Given this list of marker genes HLA-B, LMAN1, TBL1XR1, NRAS, NR1H4, SERPINC1, SLC4A1, SHOC2, AGGF1, SRD5A3, CLPB, ATP6V1A, GPC3, H19, VWF, HSD17B10, NGLY1, PROC, AMACR, PHOX2B, THBD, PEX2, PIK3CA, CACNA1S, STX5, PEX11B, HAVCR2, HLA-DQB1, SLC19A1, GBA1, GATA2, ITGB2, OSTM1, TRIP13, MCFD2, PEX10, SLC30A10, TERC, DLD, GP9, BCOR, NOP10, DKC1, MPI, MTTP, HSD3B7, PRF1, AGA, ACD, ALG6, PEX19, PEX5, RFT1, COG2, RIT1, NUMA1, PEX12, TRMU, ALG13, SLC25A13, EPB42, F2, HADH, GP1BA, TRIM28, MPDU1, VKORC1, COX16, KRAS, HLA-DQA1, SERPINF2, F8, DIS3L2, OTC, TINF2, MRAS, HRG, GATA6, RAF1, WT1, NABP1, MST1, PEX6, TEK, HACE1, TCF4, STAT2, LIN28B, COG8, ALK, F7, SEMA4D, SPRED2, FAH, HMGCL, MICOS13, ZBTB16, MPV17, EPHB2, BRCA2, ANK1, B4GALT1, MYD88 (NCBI Gene Id 4615), LMO1, NLRC4, HBB, GFI1B, EFL1, FOXP2, CFH, SPTA1 (NCBI Gene Id 6708), ORAI1, PEX3, RRAS2, LYST, MCM10, TNFRSF9, SSR4, POU6F2, RRAS (NCBI Gene Id 6237), HELLPAR, DPAGT1, SLC37A4, FGG, LARS1 (leucyl-tRNA synthetase 1), SOS1, KLKB1, FGB, ADK, GPR35, ALG8, STAT5B, F5, THBS2, PEX26, PEX13, AKR1D1, NHP2 (NCBI Gene Id 55651), F10, F9, SERAC1, P4HA2, IRF2BP2 (NCBI Gene Id 359948), PEX1, KNG1, PEX14, PRKAR1A, MEFV, SOS2, SPTB, ATP6V1E1, PTPN11, MAP2K1, FIP1L1, RINT1, ALG12, PEX16, SCARB2, ALG9, SLC7A7, MGAT2, F11, CTC1, GGCX, STXBP2, GP6, CBL, STX11, CFI, UQCRFS1, PET100, FGA, USB1, HLA-DRB1, PLOD3, ALG2, RYR1, PSMB9, PTPN22, COG4, NBAS, ALDOB, VPS33B, ACAD9, PMM2, FLNA, DPM2, ITGB3, GNE, STAT3, STIM1, TERT, CYP7B1, TYMS, RARA, RBM8A, F13B, GALT, PLG, PGM1, F13A1, ATP6V0A2, RASA2, RTEL1, REST, PARN, GP1BB, PML, AHCY, ABCD3, CD46, GNA14, PROS1, UNC13D, IKZF5, LZTR1, ABCC2, NBEAL2, DPM1, WRAP53, ANO6, NPM1, SERPINE1, XIAP, BRAF, LRPPRC, SLC25A15, VPS33A, MYCN, ITGA2B, F12 (coagulation factor XII (Hageman factor)), DDOST, FOCAD, here is a description of the gene set: studied in species Homo sapiens An abnormality of the process of blood coagulation. That is, altered ability or inability of the blood to clot. Human Gene Set: HP_ABNORMALITY_OF_COAGULATION Abnormality of coagulation